The following is a description of a gene set: Each fraction of mouse hematopoietic cells was purified by cell sorting from bone marrow of 8-week-old C57BL/6 mice, and its gene expression was analyzed. Human Gene Set: GSE27786_CD4_TCELL_VS_NKTCELL_UP studied in species Homo sapiens from publication Konuma T, Nakamura S, Miyagi S, Negishi M, Chiba T, Oguro H, Yuan J, Mochizuki-Kashio M, Ichikawa H, Miyoshi H, Vidal M, Iwama A (PMID 21540074) Genes up-regulated in comparison of CD4 T cells versus NKT cells., and this is the list of marker genes: S1PR4, GABRG1, ATP23, ZNF692, SMC4, ATP1B3, CCDC9, BRAT1, NCOR1, RGP1, DGAT2, KIF3A, SMARCC2, KIF5B, LONRF1, ENTPD5, MAP1LC3B, GMFG, ZFAND2B, INPP5F, ETS2, DHX15, OTUD7B, POLR1F (RNA polymerase I subunit F), SON, STX5, CCDC88C, HEXIM1, TNFAIP8L1, HMGB2, SLC28A2, PYCARD (NCBI Gene Id 29108), TRNAU1AP, PGPEP1L, NAA10, MTSS1, DCTN6, PCK2, RWDD2A, SDF4, PCSK1, PRICKLE1, MAPK4, ITGA6, PLCG1, SH3BGRL, AP3B2, WDR82 (WD repeat domain 82), RPA1, RNF149, TASP1, KIFAP3, TMEM161A, TGFBR2, RNF6, SLC25A47, VSTM5, RAB27A, DDI2, MEX3B, INPP4A, ZFP1, CXCR4, DPYSL2, NFKBIA, POPDC2, FAM13B, MMGT1, SLAMF1, QPRT (NCBI Gene Id 23475), AVEN, TMEM232, APRT, ADAMTS15, DNTTIP1, NAB2, NOCT, EXT1, THEMIS, IKZF4, NR4A1, SRSF7, AP3M2, CDK2AP2, ZNF691, RAD21 (NCBI Gene Id 5885), FAM118A, WDR45, SFMBT2, PDS5A, CCDC61, SLAMF6, SHROOM2, MIER1, PLEKHG2, ARHGAP31, BUD31, DCUN1D4, RIOX2, PAF1, RNF19B, CD4, SF3B1, TGIF2, CASP4, THOC7, IMP3, CEP19, SLC35B3, AP4E1, PTS, CHMP5, TIMELESS, CARMIL2, MON2, ANGPTL1, HADH, CAPG, JAZF1, ZNF326, TSSK4, SERPINB2, CALCRL, DNTTIP2, LRP10, STAR, ARHGEF28, TRIB1, P4HA1, AKAP9, DAP3, CRLF3, CASK, L3MBTL3, PIK3C2A (NCBI Gene Id 5286), DBR1, MON1A, TRPM4, SLC43A1, PEPD, ATP11A, ACAP2, MTHFD2L, TRIM59, SDHB, DCAF11, IGHM, HNRNPLL, EIF1, MAN2A2, HMG20A, PPP1R10, LZTFL1, ARL5A, MSGN1, RNASEH2A, CDC42SE2, ZC3H12D (NCBI Gene Id 387078), METTL3, MCU, TSPO2, S100PBP, SETD3, GIMAP1, RAB40B, ZNF358, ARRDC2, DGCR2, RGL2, YTHDC1, WASHC4, CD5, FCGR2B, TP53I13, MRPS18C, ECM1, TMEM50A, GRHPR, ADAMTS5, SP4, DHRS4, ATG2A, THNSL2, GREM2, NBR1, YPEL2, ITGB3, CERS5, POLR3C, PHF14, RALGPS2 (Ral GEF with PH domain and SH3 binding motif 2), SRP9, STK35, GLRX, ATP10D (NCBI Gene Id 57205), PLPP5, MINDY1, KCNC2, AK2, FDFT1